The following is a description of a gene set: electronically inferred by orthology from the curated human pathway Reactome Pathway: Acetylation part of: Phase II - Conjugation of compounds species: Mus musculus This event has been computationally inferred from an event that has been demonstrated in another species.<p>The inference is based on the homology mapping from PANTHER. Briefly, reactions for which all involved PhysicalEntities (in input, output and catalyst) have a mapped orthologue/paralogue (for complexes at least 75% of components must have a mapping) are inferred to the other species., and this is the list of marker genes: Nat2, Nat3, Nat1